Given this list of marker genes PLEC, CALM3, SIRT2, ITGB1, CNTN2, PTEN, CLDN5, PLP1, DLG1, PRKCZ, GPM6B, MAG (NCBI Gene Id 4099), PLLP, GJC2, SCRIB, HSP90AA1, STX4 (syntaxin 4), ERBB2, GJC3, CA13, CALM1, CLDN19, BCL2, CLCN2, TSPAN2, CNP, CA2, ANXA2, PRXL2B, EXOC4 (NCBI Gene Id 60412), JAM3, ERMN (NCBI Gene Id 57471), CALM2, TUBB4A, NCMAP, PMP22, MBP, PALS1, PRKCI, CALML3, MARVELD2, MAL (mal, T cell differentiation protein), MPZ, PMP2, MYO1D, GDI1, SERINC5, here is a description of the gene set: An electrically insulating fatty layer that surrounds the axons of many neurons. It is an outgrowth of glial cells: Schwann cells supply the myelin for peripheral neurons while oligodendrocytes supply it to those of the central nervous system. studied in species Homo sapiens Human Gene Set: GOCC_MYELIN_SHEATH